The following is a description of a gene set: species: Mus musculus part of: Caspase activation via extrinsic apoptotic signalling pathway electronically inferred by orthology from the curated human pathway This event has been computationally inferred from an event that has been demonstrated in another species.<p>The inference is based on the homology mapping from PANTHER. Briefly, reactions for which all involved PhysicalEntities (in input, output and catalyst) have a mapped orthologue/paralogue (for complexes at least 75% of components must have a mapping) are inferred to the other species. Reactome Pathway: Caspase activation via Death Receptors in the presence of ligand, and this is the list of marker genes: Ly96, Tradd, Ticam2, Casp8, Tlr4, Fas, Fasl, Cd14, Fadd